The following is a description of a gene set: A molecular function that controls the rate, timing and/or magnitude of gene transcription. The function of transcriptional regulators is to modulate gene expression at the transcription step so that they are expressed in the right cell at the right time and in the right amount throughout the life of the cell and the organism. Genes are transcriptional units, and include bacterial operons. Human Gene Set: GOMF_TRANSCRIPTION_REGULATOR_ACTIVITY species: Homo sapiens, and this is the list of marker genes: AHDC1, SMAD4, ZNF665, ZSCAN23, ZBED4, MAZ, OVOL3, SOX14, FOXO6, ZGPAT, FOXO3B, IRF7, ZFP82, CASZ1, PRDM10, MIER1, BHLHA9, MTA2, ZNF584 (NCBI Gene Id 201514), BCLAF3, SIX3, AHRR, ZNF668, KAT7, ZC3H8, DBX2, ZNF792, BHLHE23, ZNF454, TFB1M, WWC1, ZNF490, TRIM14, ZSCAN25, RUNX3, NSD3, ASCL4, TRIP13, ZNF446, PBXIP1, CIC, HDAC3 (histone deacetylase 3), ZNF676, IRF6, JUN, FBXL19, EWSR1 (NCBI Gene Id 2130), TGFB1I1, TPRXL, ZNF223, GBX1, KDM2A, USF1, BCOR, ZNF641, BCL9L, RBFOX2, ZNF69, PSMC3IP, PIAS3, LDB1, BSX, MGA, ZSCAN31, CBX4, MLIP, ZNF559-ZNF177, HHEX, TBX5, TLE7, SNAI2, TRIM37, SMARCA2, PRRX1, ID2, ZNF563, FOXN1, NANOGP8, ZNF680, MYCL, ZNF652, FOXE1, PAQR8, BNC1, YAP1, VHL, IRF9, HSF4, IRF5, CDCA4, TBX20, NCOA4, ELK1, PPP1R13L, BRD4, POU3F3, ZNF724, WIZ, MED26, SHOX2 (SHOX homeobox 2), ZNF101, ACSS2, ZBTB2, HINFP, ZNF431, NFE4, ZNF709, MYRF, EID1, ZNF19, POU1F1, ESR2, HCFC2, ESRRA, MEIS3P1, ZNF155, ZNF555, ASAH1, TCF24, NUPR1, ZNF217, CTNNBIP1, PBX2 (PBX homeobox 2), TOB1, E2F6, KLF1, TBL1X, ZNF469, PCBD1, DMRTC1B, LDB2, ZNF284, COPS5, CTCFL, ZBTB17, OTX1, KAT6B, NOTCH4, TP63, ZGLP1, ZNF236, FOXS1, ZNF213, MYSM1, VENTX, CTCF, MAF, ZNF646, JMJD1C, WBP2NL, TFE3 (transcription factor binding to IGHM enhancer 3), MUC1, HOXB13, PUS1, TACC1 (NCBI Gene Id 6867), JDP2, FOXB2, NPAT, SP100, WTIP, POU4F2, MED21, ZNF230, SOX3, ZNF30, ISL1 (ISL LIM homeobox 1), ZNF705D, HIRA, ANHX, PRDM11, ZNF512, BATF, APEX1, KLF3, SCAND2P, ZHX2, MYC, CTBP1, SKOR1, OVOL2, FOXO1, RYBP, NR2E1, ZNF143, ALX1 (ALX homeobox 1), FOSB, GMNN, MYBL2, ZNF433, ZNF626, ZNF90 (zinc finger protein 90), N4BP2L2, MED30, ZNF211, PARP1 (poly(ADP-ribose) polymerase 1), ZNF175, ZNF682, NACC1, PAGE4, OTP (orthopedia homeobox), ZNF195, NKX3-2, JMY, BATF3, ZFHX4, SAP30L, RUNX1, SMAD5, ATF3, NKX2-8, GLI2, ESR1, ZSCAN30, ZNF780B, ZNF512B, FHL2, MED23, TPRX1, CNOT6, ZNF131, TBXT, ZNF302, RNF14, PFDN5, NIBAN2, TFAP2E, ARID3A, CREM, SOX13, ZSCAN5DP, SSX1, NANOG, ZNF566, NFIL3, ZNF426, MED7, ZNF467, HOMEZ (NCBI Gene Id 57594, homeobox and leucine zipper encoding), SIN3B, MEIS3, JUNB, MED12, ZSCAN21, ZNF783, PROX2, GTF2A1L, SRF, ZNF613, SP1, RARG, KMT2C, ZNF692, ZNF702P, HES1, ZBTB16 (zinc finger and BTB domain containing 16), SOX30, TCF7L2, MED12L, HLX, WDR77, MYOCD, NEUROD4, KMT2D, NFKBIA, ZNF222, NR0B1, EAF1, MTA3, SOX7, RFX7, CSRNP2, POU2F1, CAMTA2, ZNF75CP, ZNF681, UTF1, SP5, ZBTB10, ABL1, TAF5L, IRX3, IKZF1, ZNF140, STK3, ATF7, SALL1, CAMTA1, TBX3, ZNF283, ZNF705B, ZNF135, ZNF581, LHX5, TGIF2, ZIC2, FOXM1 (NCBI Gene Id 2305), BICRA, HOXD4, BORCS8-MEF2B, HNF4A, TFEB, ZNF311, RCOR1, ZBED2, ZNF630, ZBTB20, HMX1, EN2, KDM2B (NCBI Gene Id 84678), ZNF275, TAF15, NEUROD1, ZNF562, HIVEP3, XBP1, NKX2-4, PPARA, NFIC, ZNF778, TFB2M, ZNF727, ZNF611, ZSCAN1, BTG1 (NCBI Gene Id 694), NOTO, SEBOX, ZNF160, E2F4, TRIM52, FOXD4L3, RBCK1, MIDEAS, EZH2, PARP9, NOC2L, MEOX1, ZNF833P, FIZ1, KLF5, TLX1, PAX4, ZNF414, MED9, NFE2L3, ZNF541 (NCBI Gene Id 84215), NR1D2, ZNF705G, FOXR2, FIGLA, ZNF619, LMO4, LPXN, MESP2, DEAF1, ASCL5, SOX6, ZNF667, NANOGNB (NANOG neighbor homeobox), TSG101, PHOX2A, ZNF876P, SP110, HNF4G, SKOR2, CALCOCO1, SMARCD2, FOXP1, ZNF595, PPARGC1A, ZNF268, ZSCAN5B, LMX1A, SP7, PRDM4, SETD4, IRX6, SP140, TLE2, ERF, GCM2 (glial cells missing transcription factor 2), CREB3L2, NFE2, ZNF790, PHF10, MYOD1, FOXD4L1, ZNF354A, ZNF85, ZNF571, HMX3, ZNF582, ZBTB43, ZBTB41, ZNF718, PCBP1, FOXH1, KLF10, ZNF132 (NCBI Gene Id 7691), HSBP1L1, ZNF542P, FOXQ1, TMF1, ZNF888 (NCBI Gene Id 388559), HOXD9, LHX4, HELT, ZNF506, ZNF296, ZNF221, SIRT1, ZNF182 (zinc finger protein 182), MAFA, ZNF202, ZNF852, ZNF419, ETS2, ZNF599, ZNF696, ETV3L, ZBTB5, GLIS1, CBFA2T3, ZNF250, FOXD4L4, SND1, ZNF347, FOXC2, KLF15, ZNF10, EGR4, PGBD1, BCORL1, TLE3, BMAL2, GMEB2, ZSCAN18, ZNF561, OVOL1, EPAS1, NFKBIB, SMAD6, TSC22D1, ZNF501, ZNF479, BRD8, RHOXF2, ZBTB49, TRAPPC2B, E2F3, MRTFB, LMX1B, HSF5, HNF1B, OR51E2, SPI1, ZNF329, RBBP8 (NCBI Gene Id 5932), HOXC9, PBX4, OSR2, ZNF121, SMARCB1, SLC30A9, ZNF181, DUXA, CREBL2, ZNF518B, CARF, FOXP2, SIM2, ZNF547, MED31 (NCBI Gene Id 51003), KDM4C, JAZF1, DNMT3A, HIC2, THAP11, SP2, SKI, HSFY1, HOXB2, FOXN4, HDGF, TP73, NSD1, RFX2, SIX5, MED20, ZNF614, LMCD1 (LIM and cysteine rich domains 1), VAX1, ZNF142, NCOA6, ZSCAN16, TCF7, CRTC1, TEAD1, NRG1, ZNF723, FERD3L, SNIP1, BACH1, TAF6L, USF3, ZBTB9, DCAF6, WWP2, MEF2A, SAP18, AASS, ABT1, FOXN2, PAX3, SNAI1, TRIM24, VSX1, PBX1, NEUROD2, ZBTB26, SPZ1, TCP10L, KLF7, HSF1, POU5F1, TCF12 (NCBI Gene Id 6938), FOXK2, RARA, SMAD7, REST, EN1, SOX21, SIX1, LMO2, PA2G4, PHF8, PKNOX1, RHOXF1 (Rhox homeobox family member 1), NR1H3, CASP8AP2, MESP1, ERFL, DLX3, RFX1, GMEB1, KLF8, NPAS4, TBX19, THRAP3, TBX18, ZNF420, EOMES, ZNF22, JUND, ZFP3, PDX1, ZXDC, USP16, MED11, PAX8, BCL11A, ZBTB7B, KMT2E, ZNF280B, RUVBL1, PEX14, ZNF430, ZNF704, SP140L, PBX3, SMAD1, TGIF2LY, ZBTB8B, RAP2C, ZNF701, MED16, WWOX, NFKB1, TRIM25, NR1I2, DPRX, ATF6B, ZNF844, HNRNPU, SOX10, CRTC2, SIRT6, RUVBL2, IRX1, HOXA3, DMRTB1, HOXD12, RELA, JPH2, HEXIM1, HES5 (hes family bHLH transcription factor 5), NR1H4, ZNF558, ENO1, CENPJ, TCF7L1, HDAC5, ARID5B, ZNF264, ZNF257, DLX2, SMARCE1, DMRTA2, SALL4 (NCBI Gene Id 57167), ATOH8, YY1, PGR, BASP1, ZNF441, NKX3-1, ZNF621, NCOA3, TLE5, TOX3, HES7, TADA2A, ZNF669, TFAP2A, FOXA1, EDF1, DMRTC1, ZMYND11, ZNF71, LBX1, BRDT, ZNF398, TSHZ2, SOX15, ZNF679, ZNF468, NUCKS1, HEY2, ZXDB, ZNF732, EBF1, ZNF543, ZNF711, FOXP4, PRDM2, BARX1, ATMIN, MYOG, ZIM2, GATA5, ZNF76, DACH1, HOXD8, DDX54, HSFX3, SFMBT2, ZFP2, ZKSCAN7, SAP30, HOXA13, NCOR1, BRD7, ASXL1, KLF4, ZNF165, ZNF496, ZNF573, ZBED1, MNT, SCAI, SOX11, ZNF416 (NCBI Gene Id 55659), ID4, DMAP1, ZNF684, HOXB5, MYT1, ZIM3, SP4, SATB2, ARID1B, ZNF536, LYL1, SMYD1, BACH2, ZNF436, TRIP11, ARID3C, BARX2, ZFX, MYBBP1A, LHX9, SCRT2, RXRG (NCBI Gene Id 6258), SRY, TLX2, MIXL1, CDX1, E2F5, ZBTB39, TFAP4, TEAD4, NR2E3, NR5A2, ZNF664, SOX9, CDC5L, GATA3 (GATA binding protein 3), ZNF443, SAV1, RIOX2, ZNF233, HOXA9, ZNF628, MYCBP, WT1, ZBTB45, NPM1, SAMD7, EVX1, FOXO4, TAF3, ZNF418, TP53BP1, CRYM, HSPA1A, PIAS1, ARNT, NPAS3, HIC1, ZBTB1, ZNF37A, GTF2IRD2B, PAQR7, JADE1, ZNF396, RIPK3, ZNF510, PEG3, ZNF492, BMAL1, TRIP4, ZNF514, ZNF534, ZNF787, ZNF546, NIPBL, IRF2, RXRB, TCF23, NACA, ZNF93, PDLIM1, POU2F3, CITED4, ZNF710, ZNF891, ZFP69B, SOX8, SALL2, ZNF746, ZFP14, RCOR2, RFX3, ZNF578, ZNF559, ZNF444, RUNX1T1, VSX2 (NCBI Gene Id 338917), HMX2, TRIM32, ARK2N, ABHD2 (NCBI Gene Id 654057), CITED2 (NCBI Gene Id 154106), ATF5, POLR2M, NR3C2, NRF1, RB1, BARHL1, MZF1, ZNF33A, MKX, ZFP30, ZNF776, SNAI3, RBM14, TRIB1, BCL11B, ZNF560, ZNF286B, ESRRB, IRF2BP1, ZNF674, NFE2L1, ATF7IP2, ZNF772, NFATC3, ZNF620, MIER2, PRMT5, BTAF1, ZNF234, ZNF671, CIR1, MTF1, CREBRF, DPF2, LEUTX (leucine twenty homeobox), GPER1, ZBTB32, ZNF404, ZNF324B, FOXI2, ZIC4, APBB1, ZNF576, ZNF780A, TWIST1, HOXA1, SIX4, ZNF146, RFXAP (NCBI Gene Id 5994), PPRC1, DBP, ENY2, ZNF215, ZKSCAN4, NFE2L2, KLF9, MITF, ELF1, MEF2C, BRCA1, SALL3, FEZF1, SP8, HSF2, ZNF460, PDE3A, ZNF688, ACTN1, HLF, AKIRIN2, HIVEP2, ZNF596, CCND1, HIPK2 (homeodomain interacting protein kinase 2), NR1D1, ADNP, DYRK1A, CITED1 (Cbp/p300 interacting transactivator with Glu/Asp rich carboxy-terminal domain 1), NFIB, CEBPG, SREBF1, ZNF251, TLX3, DRGX, HOXA7, POU4F1 (NCBI Gene Id 730659), TADA3, TOB2, IRF8 (interferon regulatory factor 8), ZNF883, TLE4, SUPT20HL1, YY2, CDY2A, STOX1, ZNF662, ZBTB7C, BBX, ARRB1, ZNF549 (zinc finger protein 549), VGLL2, ZNF148, SDR16C5, KDM7A, TCERG1L, ZNF589, PPARD, ZNF45, VDR, OLIG3, ETV3, ZHX3, GTF2I, CC2D1B, SKIDA1, SMARCC2, ZNF570, KLF17, CDX2, ZNF583, ZNF483 (NCBI Gene Id 158399), TBL1Y, CEBPE, ZNF771, ZNF610, TRIB3, ZNF799, NKX1-2, TFEC, ELANE, ZXDA, ZNF816, ZNF81, ETV2, MAFB, OLIG2, ZFY, ZIK1, SHOX, ONECUT1, PIAS2, NKX2-5, POU3F4, RXRA, OLIG1, PML, ELK3, ACTL6A, ZNF114, INSM1, ZNF764, ZNF700, ELK4, HOXA2, RARB, CARM1, ZNF232, E2F1, ZEB2, HSFX2, PRDM16, CDX4, ZNF550 (NCBI Gene Id 162972), MED15, GSX1, ID3, CUX2, ZBTB11, TWIST2, GPS2, TCF15, FOXD3, FLI1, TCFL5, AJUBA, LCOR, ZNF609, HIVEP1, CEBPA, ZBTB14, GFI1, MLXIPL, ZNF648, HSFY2, ZBTB40, MLXIP, ZNF429, CDY1, TCERG1, ZNF391, ZNF35, PIR, STAT3 (NCBI Gene Id 6774), DMRT1, ONECUT3, ELF3, GSC2, RFX4, ZNF415, PITX3, MSX2, ZNF23, RORB, PAX7, IRX5, GABPA, ZNF44, MED4, SMAD3, C1QBP, CUX1 (cut like homeobox 1), NFIA, HNF1A, ZNF324 (zinc finger protein 324), RCOR3, ZNF548, ZNF32, ANXA4, MAX, ZNF823, CDK9, PLSCR1, TAF1, SCRT1, PLAGL1, ATN1, MYT1L, ZNF282, NKX2-1 (NCBI Gene Id 7080), ZNF24, ZNF649, IRX4, ZNF239, ZNF438, ZNF14, NKX2-6, MED18, ZNF287, MEIS1, ZNF75A, TRIM38, ZNF716, HBP1, MAML3, ZNF735, ADNP2, ZSCAN20, LHX2, ZNF350, GLI1, ZNF91, ZNF133, RELB, ZNF878, ZNF124, SFMBT1, MYF5, TFCP2, REL (REL proto-oncogene, NF-kB subunit), ZBTB48 (zinc finger and BTB domain containing 48), HOXD10, PLAGL2, NKX6-2, ZNF12, SFR1, MTA1, MEIS2, ZNF100, PAWR, NEUROG3, ATOH1, GBX2, MYRFL, MAMSTR, MAGED1, ZNF677, HSFX1, NFAT5, NTN1, NFATC2, MID2, ZNF777, ZNF789, CSRNP3, VAX2, TRIM8, HAND2, NFKB2, MXD4, MED1, ZNF740, ETV1, ZBTB46, FOXB1, EP300, ZNF860 (NCBI Gene Id 731296), TBX4, SMARCC1, ZNF362, HOXD11, WBP2, SRA1, PHB1, ZNF569, TDRD3, ZNF317, FOXF1, TLE6, SIX2, GSC, ZNF763, NAB2, UNCX, NR0B2, ZNF675, SPDEF, MYF6, TFAP2C, MLX (NCBI Gene Id 6945), LEF1, POU4F3, ZNF818P, CLOCK, ZNF7, MAFG, HOXD1, PSMD9, ZNF214, ARGFX, ZNF670, ZBTB21, ZNF502, POU6F2, GPBP1, ZNF382, DMRT2, DLX5, TBR1, ZNF487, MAD2L2, ATF7IP, MED10, ZNF813, SOX17, FEV, DTX1, ZNF530, IKZF4, NR4A1, GLIS3, EID2B, ZNF705A, PRRX2, DLX1, TBX10, ZNF394, ZNF341, ING4, KCNIP3, ZNF25, HOXA5, LHX8, LHX1, ZNF655, MAP3K10, NR4A3, CREBBP, HIF1AN, NEUROD6, ZNF624, PATZ1 (POZ/BTB and AT hook containing zinc finger 1), PHOX2B, ZNF837, SOHLH2, QKI, PRDM15, FOXD4L6, CCAR1, TCF3, HES6, EGR3, ZNF527, ZNF345, CCDC62, CPHXL2, NFKBIZ, TPRX2, FOXG1, CNOT2, USP22 (ubiquitin specific peptidase 22), ZNF524, DACH2, ATOH7, MYCN, ZNF687, JUP, VEZF1, MRTFA, MYB, HYAL2, IRX2 (iroquois homeobox 2), ZHX1, ALX3, ZBTB47, HOXB6 (homeobox B6), ATF4 (NCBI Gene Id 468), HOXD13, DMRTC2, MAML1, TGIF2LX, ZNF358, ZNF79, ID1, ZNF575, PURA, BCL10, MED14, FHL5 (four and a half LIM domains 5), ZNF70, PHF24, SRSF2, CTNNB1, LPIN2, NFKBIL1, DDX17, ZBED6, PKD2, YAF2, ZNF354B, E2F8, GTF2IRD2, HELZ2, ZNF639, FOXI1, TEFM (NCBI Gene Id 79736), ASCL1, FOXL1, ASCL2, ZNF77, GON4L, HDAC7, ZNF528, RAX2 (retina and anterior neural fold homeobox 2), NEUROG1, WNT4, KMT5A, KAT2B, ZNF683, KDM5A, FOXO3, AFF3, TSHZ1 (NCBI Gene Id 791257), TP53, PRMT2 (NCBI Gene Id 3275), HOXC12, ZNF587B, PKD1, TDP2, MECP2, ZNF500, FOXD2, NFX1, AKIRIN1, KLF13, ZNF383, ZNF480, ZNF880, ZNF821, PRDM5, EAF2, TBX1, STAT1, ZNF253, SERTAD1, E4F1, ZFP69, NR2C1 (nuclear receptor subfamily 2 group C member 1), IRF1, ZNF322, BHLHE40, MAK, ZNF572, CHD4, TAF12, DMBX1, ZNF154, NFXL1, LRRFIP1, ATXN7L3, CPHXL, HOXB3, ZNF16, FUS, HOXC6, NR1H2, FOXI3, ZNF750, ZKSCAN3, MSGN1, TADA2B, GATA2, RFXANK, ZNF300, ZNF623, HES3, ZNF316, TRRAP, ZNF707, NOTCH1, RFX5, PGRMC2, SCX, RBAK, BCL6, ZNF580, THRA, ZNF805, FOSL2, TRIM5, HES4, POU6F1, LPIN1, ZNF892, ZNF281, ZFHX2, CREB1, FOXL2, DOT1L, PITX2, ZNF263 (zinc finger protein 263), SUPT7L, ZNF141, ZNF627, DMTF1 (NCBI Gene Id 9988), HOXD3, TFDP2, ONECUT2, CD274, ZNF678, GATA1, KCTD1, HES2, HMGB1, ZFP1, KLF14, ZNF616, MMS19, SOX1, PER2, ZSCAN32, TFDP3, ZMIZ2, PURG, GSX2, ZNF286A, FOXP3, NEUROG2, ZNF705EP, HSBP1, ZNF92, OTX2, ZNF66, ETV4, ZNF470, ZKSCAN2, ZNF98, NTN3, ZIC3, ZSCAN26, ZMIZ1, ZNF75D, ZBTB6, ZNF34, HIF3A, ZNF826P, ZNF57, CREB5, ZIC1, ATF2, URI1, ZNF410, ZNF442, CDY2B, NRIP1, EHF, KLF2, GATA6, KDM3A, ZNF766, TAL2, NR4A2 (nuclear receptor subfamily 4 group A member 2), TRERF1, FLYWCH1, SATB1, HAND1, ZNF835, USF2, ZSCAN4, ACTN2, MAFK, ZNF395, ZBTB37, CEBPD, TAF6 (TATA-box binding protein associated factor 6), ZNF8, PAX9, RLF, ELF2, HDAC4, ZNF497, TRIM13, ZNF343, NHLH1, TSHZ3, SOX2, HOXA4, ARX, KAT8, ZFP92, ZNF83, KDM5B, ZNF875, KAT6A, ZNF366, ZNF80, EBF3, WDR43, ZBTB34, KDM3B, DUXB (double homeobox B), DBX1, ETV7, HSFX4, SUPT20H, ELF4, HOXB9, ZNF761, ZNF654, LHX3, NRL, PROP1, ZNF367, CEBPZ, MED13L, STAT6, HOXA10, GRHL1, STAT2 (signal transducer and activator of transcription 2), FOXJ1, TRIM62, ZNF285 (zinc finger protein 285), ZNF829, PASD1, ZNF699, PMF1, ZIC5, ZNF879, KDM1A, ALX4, PQBP1, ACTL6B, HOXC4, FEZF2, ZBTB25, NKX6-3, HOXC10, POU3F1, CRX, EGR2, ETV6 (NCBI Gene Id 4348), ZNF280D, ZNF254, SOHLH1, ZFAT, ZNF730, ZNF567, SP6, DMRTA1, ZNF695, ZNF256, FOXJ2, GATA4, ZNF273, MED24, NCOA5, RRP1B, HOXB8, ZKSCAN1, EZH1, ATF6, ZFPM2, ARL2BP, TRIM31, ZNF17, SPEN, ZNF865, CREG1, ZFP42, ZSCAN2, TAF11, ZNF592, NFIX, CEBPB, ZNF491, TADA1, MEF2B, NFATC4, GRHL3, SOX12, E2F7, DMRT3, ZNF625, KLF12, ZNF425, ZFP90, PLAG1, JMJD6, ZBTB4, ZNF853, KLF18, NR6A1, BCL9, TEAD2, MYNN, ZNF568, CNOT9, HIF1A (hypoxia inducible factor 1 subunit alpha), TRIM22, ZNF672, SIN3A, IRF2BP2, CCDC124, ZNF713, HDAC1, FOXF2, EBF4, ZEB1, ETS1, RAX, MED19, ISX, ZBTB24, NR2F2, SUFU, TOX2, ZNF280A, PARP14, BIRC2, DDN, IL31RA, ASCL3 (NCBI Gene Id 56676), ZNF334, MEOX2, NFYC, INSM2, NR2F6, ZNF519, SS18L1, ATF1, RBPMS, ELF5, MTDH, PARP10, RLIM, UXT, SPIC, YEATS2, TEAD3, BCL6B, UBE3A, ISL2, NKX2-3, SKIL, MSC, PSIP1, SUB1, ZNF586, LITAF (NCBI Gene Id 9516), SIX6, DHX9, SRI, STAT4, ZNF660, ZNF471, NCOA2, CNOT7, HOXA11 (NCBI Gene Id 3207), ZSCAN9, SIM1, EMX1, ZNF449, SIAH2, ERG, ZNF516, NME2, ARID5A, ZNF653, ZNF136, NCOR2, ZNF331, ZNF320, ZNF408, MYPOP, MEF2D, ZNF74, ZSCAN22, DNAJB1, HOXC5, NKRF (NCBI Gene Id 55922), ZNF765, TCF21, ZNF180, HEY1, SSBP3, ARNT2, ZNF511, ZNF184, ZNF773, ST18, ZNF587, ZNF577, POU5F1B, ZNF337, COPS2, ZKSCAN8, IRF4, ZNF485, ZNF3, ESRRG, CTBP2, STOX2, NFYA, ZNF440, THAP1, ZNF280C, ZBTB8A, SUPT3H, ZNF266, ZNF461, BCLAF1, ZFHX3, RNF20, ZNF117, LYAR, RHOXF2B, STAT5B, CDY1B, SAMD11, TRIM27, MNX1, WWTR1 (NCBI Gene Id 25937), ZBTB12, PHF2, ZNF774, FOXR1, FHL3, ZNF737, PARK7, EVX2, DDIT3, HMGA2, MED8, ZNF736, TFCP2L1, BTG2, TBL1XR1, HESX1 (HESX homeobox 1), RERE, ZNF791, RFX6, TRIM28, NR5A1, POU2AF3 (NCBI Gene Id 120376), FOS, FOXN3, TAF9B, HDAC9, PKN1, MBTPS2, HOXC8, ZNF224, HMGB2, KAT5, ZNF177, TBX6, HOXC13, DAXX, UBE2L3, GRHL2, DLX4, SMAD9, IRF3, ACTN4, ZNF260, RUNX2, IKZF5, ZNF18, PROX1, CBFB, RORC, TBX15, ZNF518A, ZNF768, AR, NUP98, ZNF551, MED27, BARHL2, FOSL1, TFAP2D, PAX1, TEF, OSR1, FOXA3 (NCBI Gene Id 3171), NFATC1 (NCBI Gene Id 4772), PAX5, ZNF722, SOX18, NKX2-2, PHF12, ZBTB38, ZNF540, ZNF417, ZNF552, PTF1A, CDYL2 (chromodomain Y like 2), POU2AF2, ZFP57, ZFP28, MAFF, ZNF689, ZNF292, ZNF529, NAB1 (NCBI Gene Id 4664), MED17, KEAP1, DDX1, LMO3, TRIM21, ZFP41, ZNF644, NR2F1, ZBTB18, CRTC3, TDG (thymine DNA glycosylase), TLE1 (TLE family member 1, transcriptional corepressor), BCL3, MYBL1, RALY, HOXB4, GCM1, IKZF2, EMX2, CIITA, SPIB, ZNF597, ZNF439, BHLHA15, PRKCB, ZNF138, TFDP1, E2F2, GLI3, MED29, NFYB, MAML2, NPAS2, ZNF189, THRB, ZNF333, ZBED3, PURB, SMAD2, PRKN, ZNF205, ZNF785, ZNF219, LPIN3, RBPJL, SP9, ZKSCAN5, PTPN14, ZNF169, ZNF579, RREB1, ZNF397, SLC2A4RG, ZNF556, ZNF800, MECOM, SNW1, ZNF564, ARID1A, CREB3L3, TRPS1, SRCAP, ZSCAN10, ZNF304, FOXA2, EGR1, DLX6, KLF11, HEYL, FOXJ3, NFILZ, FOXK1, ZFPM1, CSRNP1, ZNF697, PAX2, HOXA6, NR3C1, NR1I3, DUX4, GZF1, NANOGP1, POU2AF1, MIER3, ZBTB33, PPARG, PAX6, PRDM8 (NCBI Gene Id 56978), ZNF248, ZMYND8, ZNF565, NOTCH2, SREBF2, BHLHE22, ZNF861P, ZNF174, ZNF607, POU3F2, C1D, FOXD4, FOXE3, ZNF714, GFI1B, SETD5, EID2, CDYL, MED22, TGIF1, PKM, TBX22, SERTAD2, ZNF784, ZNF775, PIAS4, PITX1, ZNF846, ZNF728, TFAP2B, TAL1, TAF9, USP21, KLF6, VGLL1, ZNF423, ZNF28, FOXD1, ANKRD1, TRIM15, UBP1, EBF2, LHX6, ZNF274, NOBOX, PARP15, NCOA7, HCFC1, RBPJ, MED6, NR2C2, ZNF532, SP3, PPARGC1B, KAT2A, BEND6, ESX1, PRDM1, DYRK1B, ZNF554, ZSCAN5C, HDX, HMGA1, ETV5, ARGLU1, ZNF691, ZNF517, ZBTB22, TBX21, DNMT3B, CREBZF, LIMD1, TFAM, ZBTB42, ZNF793, HOXB1, NACC2, BATF2, GLI4 (GLI family zinc finger 4, NCBI Gene Id 2738), SOX5, ZNF781, ZNF20, HR, MXD1, AEBP1, ZNF557, NKX6-1, WNT3A, AEBP2, SMARCD1, AIP, ZNF486, ZNF134 (NCBI Gene Id 7693), IKZF3, ZBTB3, MSX1, POU2F2, CREB3L4 (cAMP responsive element binding protein 3 like 4), SUPT20HL2, ZNF354C, ZNF212, ZSCAN12, GLIS2, SMARCA4, AHR, ZSCAN5A, GTF2IRD1, BUD31, ZFP37, SMARCD3, NKX1-1, SOX4, BHLHE41, CREB3, STAT5A, CC2D1A, KLF16, HOXB7, MED13 (NCBI Gene Id 9969), FOXC1, NPAS1, KCTD15, RORA, POU5F2, ZNF235, SF1, MXI1, HOXC11, TCF4, NCOA1, SS18, RFX8, MXD3, NHLH2, LBX2, CREB3L1, TBX2, CBFA2T2, XPC, SETD3, ZNF355P, LMO1, ZSCAN29, ZBTB7A, RAD54L2, MDFI, FOXD4L5, ZNF451, ZNF749